Given this list of marker genes Adcy9, Plpp6, Faim, Cox11, Xkr7, Ebf2, Add1, Stxbp1, Hmcn1, Fbxl7, Jhy (junctional cadherin complex regulator), Pdxk, Fkbp8, Cacna1b, Elavl1, Prss45, Xkr6, Epb41l4a, Pcmtd2, Eya1, Tshz3, Zmiz1, Wdr76, Izumo1r, Taok1, Chst5, Tcf23, Zfp426, Zscan21, Tasl, Klf12, Nfe2, Ermn, Alg5, Zfp128, Osbpl6, Uso1, Ap1g1, Paxbp1, Lrrc27, Fam131b, Mixl1, Zc3h4, here is a description of the gene set: from publication Chen Y, Wang X (PMID 31504780) Mouse Gene Set: MIR_7656_5P species: Mus musculus Genes predicted to be targets of miRBase v22 microRNA mmu_miR_7656_5p in miRDB v6.0 with MirTarget v4 prediction scores > 80 (high confidence targets).